The following is a description of a gene set: Naive T cells proliferate independently of cognate antigen when introduced into lymphopenic hosts. Lymphopenia-induced proliferation depends on low-affinity MHC/self-peptide complexes and on IL-7. To elucidate the intracellular signals mediating this proliferation, we analyzed changes in gene expression in naive CD8+ T cells at different times after their transfer into a lymphopenic environment. The genes induced in response to lymphopenia were largely an attenuated subset of those turned up by full antigenic stimulation, including genes related to cell cycling, whereas excluding genes specifically associated with effector activity. After the initial phase of proliferation in an empty compartment, the naive T cells adopted a stable pattern of gene expression similar to that of antigen-experienced memory cells. Thus, T cells proliferating in lymphopenic hosts do not exhibit a unique gene-expression profile, instead relying on traditional signals for this antigen-independent proliferation; this process ultimately results in differentiation to authentic memory cells. Up-regulated in CD8+ T lymphocytes undergoing homeostatic proliferation (HP) versus the naive cells; these genes are not up-regulated versus effector or memory cell population. from publication Goldrath AW, Luckey CJ, Park R, Benoist C, Mathis D (PMID 15548615) studied in species Mus musculus Mouse Gene Set: GOLDRATH_HOMEOSTATIC_PROLIFERATION, and this is the list of marker genes: Gm3325, Psmc5, Eid1, Rock1, Atp5pf, Klf9, Zrsr2, Ung, Ppa1, Igf2bp2, Ube2e1, 4930453N24Rik, Rad23b, Klra8, Vopp1, Prkca, Ndufab1, Atp6v0b, Bag2, Yme1l1, Atp11a, Set, Cacybp (NCBI Gene Id 12301), Aqp9 (aquaporin 9), Trim43a, Prps2, Nudcd2, Trnt1, Taf1d, Wipf1, Rnf11 (ring finger protein 11), Rpia, Fubp1, Nhp2, Lage3, Itgb1bp1, Ak6, App, Nifk, Pcbd2, Creb1, Eomes, Agfg1, Macroh2a1, Strn, Gk, Pdap1, Msl2, Ubl5, Rab5if (RAB5 interacting factor), Mrps33, Ndufb2, Bcl2, Gnpnat1, F2rl1, Ndufb3, Sdhc, Chek2, Pbrm1, Gmfb, Vamp4, Sos2, Amz2, Zfp62, Cmbl, Kctd12, Slc7a5, Tm9sf3, Sec62, Pdcd2, Nme1, Arl14ep, Ndufc1, Hdgf (NCBI Gene Id 99546), 1110059E24Rik, Snrpe, Tial1, Ncan, Park7, Siah1b, Rab5c, Rab18, Ubqln2, Lin7c, Irak1, Zfp131, Vti1b, 5730480H06Rik, Yipf5, Cpsf2, Sel1l (sel-1 suppressor of lin-12-like (C. elegans)), Mir5136, Rnf141, Dhx9, Golim4 (golgi integral membrane protein 4), Tgoln1, Macir, Mrps25, Impa2, Cd55, Sorl1, Bzw2, Mrpl9, Sfpq, Sema4f, Gpx1, Mpc2, Dynll2, Qdpr, Cetn3, Galk1 (NCBI Gene Id 14635), E2f1, Bysl, Il10rb (NCBI Gene Id 71442), 2310010J17Rik, Ubald2, Micos10 (mitochondrial contact site and cristae organizing system subunit 10), Nop16, Mmut, Arl4c, Smn1, Itfg1, Tmx2, Hsd3b5, Cdca7l, Fam162a, Stt3a, Nabp1, Pafah1b1, Srpra (NCBI Gene Id 67398), Sfxn1, E330034G19Rik, Pcgf2, Hnrnpa1, Dusp19, Lrp8, Hspe1, Ptges3, Reck, Ctnnd2, Pccb, Nacc2, Etfbkmt, Ebf3, Ipo7, Timm22, Npm3, Eif3j1, Cycs, Kcns2, Snx9, Vdac2, Ipp, Psmc6